Given this list of marker genes Tnip1, Lgals3, Map3k8, Srpra, Man2b1, Bcl10, Oser1 (NCBI Gene Id 66680), Stat3, Trib3, Hipk2, Hivep2, Cldn4 (claudin 4), Ptpra, Trdc, Klf10, Timp3, Sqstm1, Mgll, Edn1 (NCBI Gene Id 13614), Csrp2, Krtap6-1, Ngf, Nfkb2, Rbmxl1, Tcf25, Lamc2, Krt19, Hivep1, Rela, Cftr, Dusp16, Klf4, 2410002F23Rik, Nfe2l1, Icam1, Cxadr, Pcp4l1, Slc7a7, Btg2, Cldn7, Nfe2l2, Tnfaip3, Snhg11, Irf6, Tagln2, Cebpd, Zwint, Lcn2, Birc3, Klf6, Cish, Cx3cl1, Rab10, Mdm2, D17H6S56E-5, Anxa1, Mapkapk2, Dusp6, S100a13, Ifngr2, Nfkbiz, Prss23, Rhou, Nfkbia, Relb, Slc11a2, Spop, Tubb2a, Cxcl2, Tgfb2, Inpp5a, Sox4, Cdkn1a, Hp, Plscr1, Pvr (poliovirus receptor), Cxcl1, Sdhaf1, Bax, Wwtr1, Erbb3, Vps37b, Phlda3, Or4e2, Gjb5, Thbs1, Cd14, Pkp3, Pcgf2, Gab1 (growth factor receptor bound protein 2-associated protein 1), Stxbp1, Apaf1, Dennd2b, Atf3, Rnf19b, Irf1, Rbpj, Gnai3, Alox12, N4bp1 (NCBI Gene Id 97462), Galc, Ocln, Btg1, B4galnt1, Rnf19a, Traf3, Sinhcaf, Plk2, Junb, Acta2, Socs2, Rnps1, Pde4b, Sprr1a, Dsc2, Tacstd2, Rlim, Rell1, Capn3, Nfkbib, Gpcpd1, Rab5b, Gna13, Klf5, Tgif1, Dennd5a, Csf1, here is a description of the gene set: species: Mus musculus from publication Rashi-Elkeles S, Elkon R, Weizman N, Linhart C, Amariglio N, Sternberg G, Rechavi G, Barzilai A, Shamir R, Shiloh Y (PMID 16314843) Mouse Gene Set: RASHI_RESPONSE_TO_IONIZING_RADIATION_2 The ATM protein kinase, functionally missing in patients with the human genetic disorder ataxia-telangiectasia, is a master regulator of the cellular network induced by DNA double-strand breaks. The ATM gene is also frequently mutated in sporadic cancers of lymphoid origin. Here, we applied a functional genomics approach that combined gene expression profiling and computational promoter analysis to obtain global dissection of the transcriptional response to ionizing radiation in murine lymphoid tissue. Cluster analysis revealed a prominent pattern characterizing dozens of genes whose response to irradiation was Atm-dependent. Computational analysis identified significant enrichment of the binding site signatures of NF-kappaB and p53 among promoters of these genes, pointing to the major role of these two transcription factors in mediating the Atm-dependent transcriptional response in the irradiated lymphoid tissue. Examination of the response showed that pro- and antiapoptotic signals were simultaneously induced, with the proapoptotic pathway mediated by p53 targets, and the prosurvival pathway by NF-kappaB targets. These findings further elucidate the molecular network induced by IR, point to novel putative NF-kappaB targets, and suggest a mechanistic model for cellular balancing between pro- and antiapoptotic signals induced by IR in lymphoid tissues, which has implications for cancer management. The emerging model suggests that restoring the p53-mediated apoptotic arm while blocking the NF-kappaB-mediated prosurvival arm could effectively increase the radiosensitivity of lymphoid tumors. Cluster 2: late ATM dependent genes induced by ionizing radiation treatment.